Given this list of marker genes Cfdp1 (craniofacial development protein 1), Fhdc1, Cxcl16, Unc80, Myo16, Smad5, Sit1, here is a description of the gene set: Mouse Gene Set: MIR_741_5P from publication Chen Y, Wang X (PMID 31504780) species: Mus musculus Genes predicted to be targets of miRBase v22 microRNA mmu_miR_741_5p in miRDB v6.0 with MirTarget v4 prediction scores > 80 (high confidence targets).